Given this list of marker genes Mpv17, Twnk, Atg7, Mettl4, Pif1, Rrm1, Cfh, Tymp, Ssbp1, Mrpl17, Gimap3, Dna2, Mgme1, Mtnap1, Rnaseh1, Mef2a, Primpol, Dnaja3, Polg2, Rrm2b, Trp53, Mrpl15, Top3a, Polg, Parp1 (NCBI Gene Id 98479), Endog, Slc25a33, Neurl4, Sesn2, Akt3, Tk2 (NCBI Gene Id 57813), Stox1, Chchd4, Lig3, Slc25a36, Opa1, Mrpl39 (mitochondrial ribosomal protein L39), here is a description of the gene set: The maintenance of the structure and integrity of the mitochondrial genome; includes replication and segregation of the mitochondrial chromosome. studied in species Mus musculus Mouse Gene Set: GOBP_MITOCHONDRIAL_GENOME_MAINTENANCE